Given this list of marker genes RNF2, GARS1, ZBTB20, ELOVL1, STOML3, ARL17A, TXNRD1, TDP2, SCYL3, PHF12 (NCBI Gene Id 57649), C9orf50, ARHGAP33, GANC, PCSK1N, SEMA4G, TMEM218, CYP26B1, MDK, FRMD4B, IQGAP3, GDF2, IDH3A, SETD5, NEFL, DNMT3B, HBEGF, ZNF138, STUM, PPP1R2, C19orf84, NCBP3, LYNX1-SLURP2, KAT7, ADAMTS14, FGD1, MPL, CD1E, AUNIP, CPNE5, IGF2, ZBTB4, KMT2B (lysine methyltransferase 2B), ENSG00000187185, MSN, TTC22, BSDC1, MYLIP, PPP1R3B, ARL17B, NECTIN1, MEX3A, KYAT1, KCNT2, MTSS1, RND2, LIMD2, SLC6A3, ARF3, DSCAML1, ECH1, SLURP2, RIMOC1, CRISPLD2, IFI44L (interferon induced protein 44 like), TNFSF8, AKT1S1, CNGB3, FAM218A, PLXNA2, PDK4, C4orf19, JADE1, C2orf88, DNAJA2, VWF, CHST14, SEMA6A, PIP4P1, HCFC1R1, PARVA, NTSR1, ERF, here is a description of the gene set: Genes predicted to be targets of miRBase v22 microRNA hsa-miR-6796-5p in miRDB v6.0 with MirTarget v4 prediction scores > 80 (high confidence targets). from publication Chen Y, Wang X (PMID 31504780) studied in species Homo sapiens Human Gene Set: MIR6796_5P